The following is a description of a gene set: part of: Platelet calcium homeostasis During steady state conditions, cytoplasmic is reduced by the accumulation of Ca2+ in intracellular stores and Ca2+ extrusion. studied in species Homo sapiens Reactome Pathway: Reduction of cytosolic Ca++ levels, and this is the list of marker genes: ATP2A3, ATP2B3, SLC8A2, ATP2B1, CALM1, SRI, SLC8A1, SLC8A3, ATP2B4, ATP2A1, ATP2A2, ATP2B2